The following is a description of a gene set: Matrisome proteins found in significantly higher abundance in TNBC brain, bone, liver and lung metastatases compared to normal samples. Human Gene Set: HEBERT_MATRISOME_TNBC_BONE_BRAIN_LIVER_LUNG_METASTASTASES We have previously developed methods for enriching tissue samples for their ECM protein content by taking advantage of the relative insolubility of the ECM, and we have used these techniques in conjunction with mass spectrometry-based proteomics to profile the matrisome, the complete collection of both core ECM and ECM-associated proteins, in several different cancers. Here we define and compare the ECM components of metastatic niches and how they differ among the specific secondary sites common in TNBC. For this purpose, we use as a model the MDA-MB-231 human TNBC cell line, originally derived from a patient pleural effusion (24), which is capable of metastasizing to the brain, lungs, liver and bone marrow in mouse xenografts. We identify which ECM proteins are commonly elevated at multiple different metastatic sites, and which are preferentially elevated in particular sites. We investigate how these specific ECM proteins, as well as the tumor matrix overall, are differentially produced by the tumor and stromal cells; in this paper, we use stromal to include all cells in the tumor that are not tumor cells. These comparisons did not simply identify the most elevated proteins in each tissue, but rather the proteins most significantly different in abundance in one tissue relative to all others. Separate analyses were conducted for tumor-cell-derived (human) and stroma-derived (mouse) proteins. In this study, we performed an unbiased, quantitative mass spectrometric survey of ECM proteins present in MDA-MB-231 breast cancer xenograft metastases to the brain, lungs, liver and bone marrow. This gene set lists the matrisome proteins found in significantly higher abundance in TNBC brain, bone, liver and lung metastatases compared to normal samples. from publication Hebert JD, Myers SA, Naba A, Abbruzzese G, Lamar JM, Carr SA, Hynes RO (PMID 32019869) species: Homo sapiens, and this is the list of marker genes: SERPINB1, FGF2, ANXA2, S100A4, TINAGL1 (NCBI Gene Id 64129), HSPG2, ADAMTSL1, NID1, ANXA1, DPT, NPNT, CTSD, COL4A1